Given this list of marker genes Gk, Adm2, H2bw2, Abcb11, Ripk1, Ube2l3, Myo1d, Ints15, Calhm4, Dgkb (NCBI Gene Id 217480), Ttyh3, Cnih1, Gjb2, Isg20, Nova2, Ptrhd1, Got1, Dmrtc1a, Syt6, Daam2, Olah, Cntfr, Rmdn1, Atxn7, Emp1, Pan3, Ercc6, Gzmb, Garin1a, Rnf11, Wnk3, Syce2, Slc24a3, Stat5b (NCBI Gene Id 20851), Lrch1, Epha7 (Eph receptor A7), Pold4, Ctnnb1, Plod1, Gdap2, Sdk1, C330018D20Rik, Rfesd (Rieske (Fe-S) domain containing), Onecut2, Upb1 (ureidopropionase, beta), Pmp22, Hmg20a, Prpf40a, Sema6d, Mapk10, Chmp6, Vps16, Trim12a, Shisa7, Clasp1, Cldnd1, Ado (NCBI Gene Id 211488), Rasef (NCBI Gene Id 242505), Zfp282, Plin4 (NCBI Gene Id 57435), Cd82, Nfasc, Rybp (NCBI Gene Id 73651), Zfp36l2 (zinc finger protein 36, C3H type-like 2, NCBI Gene Id 12193), Orai2, Tmem198, Ceacam20, Lrrc55, Baz2b, Cd28, Ccdc127, Plekhh1, C1qtnf3, Rab27b, Ppp6r3, Srgap3, Cyp4a31, Dgkk, Mixl1, Srcap, Tet3, Sez6, Oxgr1, Tardbp, Lmnb2, Epg5, Ankrd23, Plxnd1, Cfap418, Rnf13, Adcy1, Agtpbp1, Cr2, Pfkp, Chd3, Gnal, Pcdh17, Car7, Calu, Lrfn4, Gatad2a, Gpr26, Pknox2 (NCBI Gene Id 208076), Usp31, Lcn9, Ankrd33b, Trim32, Herc6, Ube3a, Dpf1, Vezt, Gid4, Dkc1, Slc6a8, Sugt1 (SGT1, suppressor of G2 allele of SKP1 (S. cerevisiae)), Slc6a19os, Tbc1d24, Cnot2, here is a description of the gene set: Mouse Gene Set: MIR_546 Genes predicted to be targets of miRBase v22 microRNA mmu_miR_546 in miRDB v6.0 with MirTarget v4 prediction scores > 80 (high confidence targets). studied in species Mus musculus from publication Chen Y, Wang X (PMID 31504780)